The following is a description of a gene set: Hypochromic microcytic anemia A type of anemia characterized by an abnormally low concentration of hemoglobin in the erythrocytes and lower than normal size of the erythrocytes. Human Gene Set: HP_HYPOCHROMIC_MICROCYTIC_ANEMIA species: Homo sapiens, and this is the list of marker genes: TAFAZZIN, LPIN2, KARS1, HBB, ABCB7, TRNT1 (tRNA nucleotidyl transferase 1), TMPRSS6, HBG2, HSCB, HBA2, ALAS2, HBA1, SHPK, DNAJC19, KLF1, OSTM1, BCL11A, C2orf69 (chromosome 2 open reading frame 69), HBG1, ATRX, CP, CARD10